Given this list of marker genes C4orf46, TTK, PIMREG, PDAP1, PSD2, VDAC3 (NCBI Gene Id 7419), ORC6, SMARCD2, ZC3H8, EMC4, RRAS2, COQ7, GLYCTK, CDC20B, SKIC2 (NCBI Gene Id 6499), KHDRBS3, NUCB1 (NCBI Gene Id 4924), ANLN, DNAJC9, SALL3, CSE1L, PPIH, WDR89, YKT6 (YKT6 v-SNARE homolog), MGMT, NSMCE2, TUBB, KCNC2, ADAMTSL5, GSPT1, BUB3, TK1, PRC1, KIF2C, YPEL2, FIGNL1, EXOSC8, MYO5A, CTPS1, SPIDR, PLK4, HNRNPUL2, KIF4A, ERAL1, STAG2, NANS, ALDH16A1, E2F7, CCDC18, NFIL3, FKBP2, GGA2, PRIM2, NOL7, GRPEL1, PAF1, MAOA, ARMT1, CDC123, RUVBL2, CAND1, SVOPL, LY96, HNRNPA0, DENR, HERPUD1, STK35, HIGD2A, SLC10A7, CCNA2, SCAF1, GPSM2, PRUNE1, TARS2 (NCBI Gene Id 80222), SMARCAD1, PPP4R2, TIMM17B, RAP1GDS1, MRPL55, TAF7, ASS1, KPNA1, ZNF395, BET1, ZNF771, MRPL35, PCYOX1, PLA1A, CDC73, KIF18A, CRYBG1, PARPBP, FAM98A, ABHD10, CSRP3, ZMIZ2, SYN2, TDP1, TPX2, BRF1, SLC18A2, MXD3, CDK4, FAM204A, TMX1, FAM149B1, KANSL3, IFT57, NKAP, LRRC40 (leucine rich repeat containing 40), C14orf93, ACBD6 (acyl-CoA binding domain containing 6), MCM8, MAGOHB, KARS1, LAS1L, SACM1L, MACO1, RTKN2, INTS8, CUL4B, CDO1, DSEL, SGCE, MCOLN1, KAT7, SFMBT1, ZNF704, NUCKS1, PCGF1, HS6ST3, CDH7, SGO1, RIOX1, TIMM50, ZNF141, APOOL, BTBD9, KIFC2, RASL12, ENPP6, PPA2, ILF2, TOP2A, KIAA1549L, OSGIN2, IRF4 (interferon regulatory factor 4), FBXO45, PLK1, GNL2, NMRAL1, ZMYM1, MDH1, RAB9A, LONRF1, NXT2, ZWILCH, GATA6, RBBP5, NINJ2 (ninjurin 2), KYAT3, PPFIA3, METTL4, RBL1, SERBP1, MAGEF1, SAMD1, SPC25, CLXN, HAUS6, TAF13, MOAP1, CLUAP1, CDC25B, DENND2C, KCND2, CNTLN, UGGT1, MTCH2 (mitochondrial carrier 2), NCAPD2, BCCIP, ECHDC1, HEXIM1, LEMD1, KCTD20, CEP89, ALDH3A2 (NCBI Gene Id 224), VPS72, EFTUD2, KEAP1, TSSK2, SMC2, RAD23A, CA5B, E2F2, SCMH1 (Scm polycomb group protein homolog 1), AURKB, C19orf47, HMGB4, CDK2, here is a description of the gene set: Human Gene Set: GSE2770_IL12_AND_TGFB_VS_IL4_TREATED_ACT_CD4_TCELL_6H_UP Th1 and Th2 cells arise from a common precursor cell in response to triggering through the TCR and cytokine receptors for IL-12 or IL-4. This leads to activation of complex signaling pathways, which are not known in detail. Disturbances in the balance between type 1 and type 2 responses can lead to certain immune-mediated diseases. Thus, it is important to understand how Th1 and Th2 cells are generated. To clarify the mechanisms as to how IL-12 and IL-4 induce Th1 and Th2 differentiation and how TGF-beta can inhibit this process, we have used oligonucleotide arrays to examine the early polarization of Th1 and Th2 cells in the presence and absence of TGF-beta after 0, 2, 6 and 48 hours of polarization. species: Homo sapiens Genes up-regulated in CD4 T cells activated by anti-CD3 and anti-CD28: TGFB1 and IL-12 (6h) versus IL4 (6h). from publication Lund R, Aittokallio T, Nevalainen O, Lahesmaa R (PMID 14607935)